Given this list of marker genes CAPZA2, DDOST, S100A12, MAPK3, SAA1, HMGB1, MAPK1, LGALS3, AGER, CAPZA1, S100B, PRKCSH, APP, here is a description of the gene set: Reactome Pathway: Advanced glycosylation endproduct receptor signaling Advanced Glycosylation End- product-specific Receptor (AGER) also known as Receptor for Advanced Glycation End-products (RAGE) is a multi-ligand membrane receptor belonging to the immunoglobulin superfamily. It is considered to be a Pattern Recognition Receptor. It recognizes a large variety of modified proteins known as advanced glycation/glycosylation endproducts (AGEs), a heterogenous group of structures that are generated by the Maillard reaction, a consequence of long-term incubation of proteins with glucose. Their accumulation is associated with diabetes, atherosclerosis, renal failure and ageing. The most prevalent class of AGE in vivo are N(6)-carboxymethyllysine (NECML) adducts. In addition to AGEs, AGER is a signal transduction receptor for amyloid-beta peptide (Ab), mediating Ab neurotoxicity and promoting Ab influx into the brain. AGER also responds to the proinflammatory S100/calgranulins and High mobility group protein B1 (HMGB1/Amphoterin/DEF), a protein linked to neurite outgrowth and cellular motility.<br><br>The major inflammatory pathway stimulated by AGER activation is NFkappaB. Though the signaling cascade is unclear, several pieces of experimental data suggest that activation of AGER leads to sustained activation and upregulation of NFkappaB, measured as NFkappaB translocation to the nucleus, and increased levels of de novo synthesized NFkappaB. As this is clearly an indirect effect it is represented here as positive regulation of NFkappaB translocation to the nucleus. AGER can bind ERK1/2 and thereby activate the MAPK and JNK cascades. studied in species Homo sapiens part of: Innate Immune System